The following is a description of a gene set: Human Gene Set: GOBP_PRIMARY_ALCOHOL_METABOLIC_PROCESS species: Homo sapiens The chemical reactions and pathways involving primary alcohols. A primary alcohol is any alcohol in which a hydroxy group, -OH, is attached to a saturated carbon atom which has either three hydrogen atoms attached to it or only one other carbon atom and two hydrogen atoms attached to it., and this is the list of marker genes: BMP5, SCNN1B, BCO1, WNT4, PARK7, DHRS7, CYP27C1, RDH8, SDR9C7, AKR1C4, GDE1, DAB2, DHRS9, PECR, RDH16, CYP11B2, CLCN2, NAPEPLD, ALDH3B1 (NCBI Gene Id 221), EDNRB, RBP4, CYP3A7, CYP2C8, CYP11B1, BMP6, CACNA1H, H6PD, SULT1A1, AKR7A2, HAO1, SULT1E1, ALDH1A3, RDH13, PNPLA4, NAAA, AKR1B1, RETSAT, HSD17B6, BMP2, RDH10, DGKQ, HSD11B2, SULT1A4, ACP3, CYP1A2, SDR16C5, ALDH2, CYP2D6, TPK1, RDH12, THTPA, ALDH1A1, ALDH1B1, PNLIP, CYP1B1, CYP2C18, CEL, ADH4, AKR1A1, AKR1B10, AKR1C1, ADH6, PLB1, ADH7, ACSS1, DHRS3, ADH1A, SULT1B1, DKK3, RDH5, CBR4, ALDH1A2, AKR1B15, REST, SULT1A2, IGF1, AWAT2, TKTL1, AKR1C3, SULT1C4 (NCBI Gene Id 27233), CYP3A5 (NCBI Gene Id 1577), CYP1A1, PNPLA2 (patatin like phospholipase domain containing 2), RDH11, SULT1A3, ACSS2, AKR1C2, ALDH3A2, ALDH3B2, LRAT, SULT2A1, CYP3A4, RDH14, DGAT2, DHRS4, RPE65 (NCBI Gene Id 6121), CYP11A1, ADH1B, GDPD1, GDPD3 (NCBI Gene Id 79153), DGAT1, ADH1C, LIPE